The following is a description of a gene set: Mouse Gene Set: GOBP_B_CELL_DIFFERENTIATION studied in species Mus musculus The process in which a precursor cell type acquires the specialized features of a B cell. A B cell is a lymphocyte of B lineage with the phenotype CD19-positive and capable of B cell mediated immunity., and this is the list of marker genes: Cdh17, Onecut1, Ptprj, Irf2bp2, Aqp8, Gps2 (G protein pathway suppressor 2), Malt1, Prkdc, Nfatc1, Ighe, Flt3l, Dock10, Plcl2, Hhex, Clcf1, Zbtb7a, Dclre1c, Nhej1, Dll1, Spi1, Zfp36l1, Gon4l, Mir19a, Rag2, Ptpn6, Itfg2, Ddrgk1, Pnp, Cyld, Dpp4, Tnfaip3 (tumor necrosis factor, alpha-induced protein 3), Il10, Bcl3, Lgals8, Tnfsf13b, Pik3r1, Nfkbiz, Traf3ip2, Ppp2r3c, Sfrp1, Mir20a, Cmtm7, Fzd9, Dnajb9, Ms4a1, Msh2, Lfng, St3gal1, Tcirg1, Mir18, Cd40lg, Gm11690, Slamf8, Bak1, Il2rg, Ada, Muc19, Abl1, Phf14, Bax, Slc39a7, Ezh2, Gpr183, Irf8, Laptm5, Ikzf1, Il7, Adam17, Igkj5 (immunoglobulin kappa joining 5), Yy1, Syk, Rag1, Slc25a5, Il4i1, Nckap1l, Tpd52, Stat5b, Ep300, Enpp1, Lrrc8a, Nkx2-3, Trp53, Atm, Hmgb3, Jak3, Ahr, Xbp1, Top2b, Atp11c, Ntrk1, Mir150 (microRNA 150), Rabl3, Il9r, Inpp5d, Mfng, Bcl11a, Tlr9, Itm2a, Lgals1, Flt3, Foxp1, Ptpn2, Hdac5, Mir92-1, Ikzf3, Pcid2, Il9, Cd19, Il6, Cr2, Ighg1, Bad, Hmga1, Syvn1, Il21, Myb, Adgrg3, Ptprc, Lyl1, Gimap1, Cebpg, Bcl6, Ighm, Cd79b, Card11, Dcaf1, Dock11 (NCBI Gene Id 75974), Il2, 6030468B19Rik, Cd79a, Hdac9, Mir19b-1, Btk, Lilrb4a, Cd27, Hdac7, Fas, Pou1f1, Ankle1, Tcf3, Sp3, Ifnz, Spib, Notch2, Pou2af1, Fnip1, Zbtb1, Mmp14, Id2, Stat5a, Igkc, Zfp36l2, Nfam1, Bcl2, Pou2f2, Fosl2, Rbpj, Cd24a, Mir17, Ptk2b, Tshr, Plcg2, Kit, Polm